Given this list of marker genes UBC, NGFR, PRKCI, RIPK2 (receptor interacting serine/threonine kinase 2), NFKB1, IRAK1, TRAF6, IKBKB, RELA, MYD88, UBB, NGF, UBA52, SQSTM1, NFKBIA, RPS27A, here is a description of the gene set: Reactome Pathway: p75NTR signals via NF-kB part of: p75 NTR receptor-mediated signalling studied in species Homo sapiens The NF-kB pathway is an important pro-survival signalling pathway activated by mature NGF, but not BDNF or NT-3, through p75NTR. It is unclear whether TRKA activity also affects NF-kB activation.